The following is a description of a gene set: species: Mus musculus Mouse Gene Set: GOBP_NEGATIVE_REGULATION_OF_PROTEIN_EXIT_FROM_ENDOPLASMIC_RETICULUM Any process that stops, prevents, or reduces the frequency, rate or extent of the directed movement of proteins from the endoplasmic reticulum., and this is the list of marker genes: Ube2j1, Insig1, Svip, Derl2, Yod1 (NCBI Gene Id 76190), Derl3, Ubac2, Erlec1, Ube2g2, Os9